Given this list of marker genes SMARCA5, USP36, BAZ2A, RRN3, ACTR6, PHF2, BEND3, MACROH2A1, DDX11, PHF8, NOLC1, SIRT2, SUV39H1, POLR1B, RPS19, EMG1, SIRT1, RRP8, here is a description of the gene set: Human Gene Set: GOBP_NUCLEOLUS_ORGANIZATION A process that is carried out at the cellular level which results in the assembly, arrangement of constituent parts, or disassembly of the nucleolus. species: Homo sapiens